The following is a description of a gene set: Human Gene Set: ROVERSI_GLIOMA_LOH_REGIONS Genes in the most frequently heterozygous deleted loci of a panel of glioma cell lines. Identification of genetic copy number changes in glial tumors is of importance in the context of improved/refined diagnostic, prognostic procedures and therapeutic decision-making. In order to detect recurrent genomic copy number changes that might play a role in glioma pathogenesis and/or progression, we characterized 25 primary glioma cell lines including 15 non glioblastoma (non GBM) (I-III WHO grade) and 10 GBM (IV WHO grade), by array comparative genomic hybridization, using a DNA microarray comprising approx. 3500 BACs covering the entire genome with a 1 Mb resolution and additional 800 BACs covering chromosome 19 at tiling path resolution. Combined evaluation by single clone and whole chromosome analysis plus 'moving average (MA) approach' enabled us to confirm most of the genetic abnormalities previously identified to be associated with glioma progression, including +1q32, +7, -10, -22q, PTEN and p16 loss, and to disclose new small genomic regions, some correlating with grade malignancy. Grade I-III gliomas exclusively showed losses at 3p26 (53%), 4q13-21 (33%) and 7p15-p21 (26%), whereas only GBMs exhibited 4p16.1 losses (40%). Other recurrent imbalances, such as losses at 4p15, 5q22-q23, 6p23-25, 12p13 and gains at 11p11-q13, were shared by different glioma grades. Three intervals with peak of loss could be further refined for chromosome 10 by our MA approach. Data analysis of full-coverage chromosome 19 highlighted two main regions of copy number gain, never described before in gliomas, at 19p13.11 and 19q13.13-13.2. The well-known 19q13.3 loss of heterozygosity area in gliomas was not frequently affected in our cell lines. Genomic hotspot detection facilitated the identification of small intervals resulting in positional candidate genes such as PRDM2 (1p36.21), LRP1B (2q22.3), ADARB2 (10p15.3), BCCIP (10q26.2) and ING1 (13q34) for losses and ECT2 (3q26.3), MDK, DDB2, IG20 (11p11.2) for gains. These data increase our current knowledge about cryptic genetic changes in gliomas and may facilitate the further identification of novel genetic elements, which may provide us with molecular tools for the improved diagnostics and therapeutic decision-making in these tumors. from publication Roversi G, Pfundt R, Moroni RF, Magnani I, van Reijmersdal S, Pollo B, Straatman H, Larizza L, Schoenmakers EF (PMID 16247447) species: Homo sapiens, and this is the list of marker genes: GPRC5D, ANO5, HEBP1, EPHA5, PSMC6, PDPN (podoplanin), GUCY2C, PVR, HTATIP2, ARAP2, GPRC5A, ABCC9, SLC17A6, GSG1, ATF7IP, KCNJ8, GRIN2B, ADAMTS3, PRDM2, MUC15, PTTG2, CNTN4, NPFFR2, ADGRL3, GAS2, IL5RA, ATXN1, TRNT1, TBC1D1, GC, DDHD1, FANCF, SLC6A5, NELL1, GMPR, LDHB, EMP1, CENPC, MYLIP, GNPNAT1, PPFIBP1, PRMT3, LRRN1, STYX, FERMT2